The following is a description of a gene set: species: Homo sapiens Proteins that have been synthesized, processed and sorted eventually reach the final steps of the secretory pathway. This pathway is responsible not only for proteins that are secreted from the cell but also enzymes and other resident proteins in the lumen of the ER, Golgi, and lysosomes as well as integral proteins transported in the vesicle membranes. part of: trans-Golgi Network Vesicle Budding Reactome Pathway: Golgi Associated Vesicle Biogenesis, and this is the list of marker genes: CLTA, HSPA8, NECAP1, YIPF6, SNX2, CPD, HIP1R, PIK3C2A, BLOC1S6, OCRL, SNAPIN, BLOC1S3, SORT1, AP3B1, TXNDC5, TFRC, AP4E1, FTH1, SH3D19, CLINT1, AP1B1, ARRB1, FTL, BLOC1S1, RAB5C, TPD52L1, VAMP2, NAPA, IGF2R, DNAJC6, TBC1D8B, AP1M1, DTNBP1, VAMP7, ARF1, BLOC1S4, AP1S2, SNX5, GOLGB1, SNX9, TGOLN2 (NCBI Gene Id 10618), VAMP8, PUM1, ACBD3, AP3S1, AP1G1, AP1S3, CLTC (clathrin heavy chain), AP1M2, TPD52, GAK, AP4B1, SH3GL2, PICALM, AP1S1, DNM2